The following is a description of a gene set: Fusion of cervical vertebrae at C2 and C3, caused by a failure in the normal segmentation or division of the cervical vertebrae during the early weeks of fetal development, leading to a short neck with a low hairline at the back of the head, and restricted mobility of the upper spine. Human Gene Set: HP_CERVICAL_C2_C3_VERTEBRAL_FUSION Cervical C2/C3 vertebral fusion studied in species Homo sapiens, and this is the list of marker genes: MEOX1, GDF3, CDH11, GDF6, ASH1L, BRPF1, TBX5, AEBP1, DKK1, ASXL2, AFF4, FLNA, MYO18B